The following is a description of a gene set: Human Gene Set: FAN_OVARY_CL15_SMALL_ANTRAL_FOLLICLE_GRANULOSA_CELL studied in species Homo sapiens The GC of small antral follicles (1-2_mm diameter) clustered pronouncedly in cluster (CL15) showing WT1high/EGR4high/VCANlow/FSTlow expression (Fig. 4b), suggesting that at that stage mural and cumulus GC still have a common progenitor (pGC) signature. from publication Fan X, Bialecka M, Moustakas I, Lam E, Torrens-Juaneda V, Borggreven NV, Trouw L, Louwe LA, Pilgram GSK, Mei H, van der Westerlaken L, Chuva de Sousa Lopes SM (PMID 31320652), and this is the list of marker genes: STMN1, RPL17, PHF6, ANKRD10, MT-CO1, PPP1R13L, NXF1, ACSL3, ARF5, SMARCA1, SOX4, DNAJB6, DYNLL1, PMAIP1, METAP2, GADD45B, TCEA3, VPS29, TOR1AIP2, ARPC5L, MIF, SMNDC1, ELOB, HIKESHI, SKIL, ACTB (actin beta), NR5A2, MTCH1, DCTN6, EGR3, NDUFA4, TCP1, CFAP20, NOP58, AMHR2, SERTAD3, ZBTB10, MAPRE1, SNRPF, MT-CO2, PABPN1, LSR, MFAP2, HNRNPA1, JPT1, H4C3, MOAP1, LMBR1L, BCL2L12, GHITM, ISYNA1 (inositol-3-phosphate synthase 1), ZFAND6, THAP9-AS1, ANXA6, TMEM41B, GMNN, ACADM, FUBP1, NDUFB6, BZW1, AKIRIN2, LUC7L3, TCEAL2, AKIRIN1, MGST3, LY6E, RASL11B, CYRIB, BUD31, HOPX, SQLE, RBM39, DUOX1, CHRM3, SNRPG, ATP1B1, UBE2D3, CDK6, FNDC3B, CAMTA1, EIF4G2, TIMM17A, ARPC5, CTNNAL1, ZNF711, KRT18, STK17B, MYL12B, CPSF6, PSMA3, CDH3, HIF1A, HSP90AB1, STIP1, SNRPE (small nuclear ribonucleoprotein polypeptide E), SINHCAF, NME2, RANBP1, MT-ND3, DYNLT1, SAT2, HSD17B1, PFN1, FBXO32, IFT25, USP9X, U2SURP, SARNP, BAMBI, KDM5A, DSP-AS1, STRAP, MAGED2, CHSY1, RABGGTB (Rab geranylgeranyltransferase subunit beta), MYO10, SNRPN, MTRF1L, GNAI3, FRMD4B, HIGD1A, YTHDC1, RAB2A, PPP2CA, SRPX, ARIH1, PNRC2, CD164, EGR4, SRI, ARL4D, METTL21A, RALB, RBM7, EFNB2, MAFF (MAF bZIP transcription factor F), CKS2, ATP5PF, IFI27L1, NCKAP5L, HNRNPH1, EXT1, ATP5MG, HMGCR, TMEM97, APOA1, INHBB, CHIC2, TAX1BP1, KIF1B, RBBP7, TJP1, PDZRN3, SUMO1, KPNA3, PSPC1, PPP1R14A, SOWAHC, YWHAB (NCBI Gene Id 7529), ATP1A1, MARCKSL1, ZNG1B, ZNF326, UQCRH, IFNGR2, CCNL1, DPM1, OSGIN2, G3BP2, PRDX2, IST1, SLC16A1, RAD23B, ODR4, TPRKB (TP53RK binding protein), PRKAR2B (protein kinase cAMP-dependent type II regulatory subunit beta), ME2, THUMPD3-AS1, MARK3, HSPE1, WASF3, CSPP1, MAP3K13, DNAJA4, PFDN4, SLC25A5, ACTG1, RUNX1, SRSF10, POR, SF3B6, TEAD1, BEX1, OSER1 (oxidative stress responsive serine rich 1), PTGER2, DIPK2A, AHSA1, WT1, SNRPB, RBM8A, NECTIN2, MARCHF7, CDKN2AIP, ARHGAP18, SKP1, FOSL2, PDRG1, TSC22D2, PAIP1 (poly(A) binding protein interacting protein 1), PPP1R15A, SLC39A8, HNRNPM, DSP, LSM5, PPA1, RBP1, MED13L, DNAJB1, B3GNT2, EEF1B2, MSH6, CCND2, HNRNPK, HSBP1, CKB, COX7B, RCN2, UBC, ARF4, MARCHF5, TMEM14A, CBX3, PLIN3, ARPC2, ZFAND2A, INHA, ATG101, AK6, CLK1, ACSL4, NBEAL1, AJUBA, TMEM126A, MPC2, PSMD14, LUC7L, USP16, RNMT, AFF4, HOMER1, HSP90B1, RPRD1A, ZC3HAV1, YAF2, TIMM23, COMT, BCAR3, NICOL1, MGARP, LAPTM4B, RPL27A, GPR89B, LRRC8C, DDX52, ZNF593, TMEM60, GRIK1, GNAI1, ARL6IP1, P3H2, DNAJA1, NET1, ZFAND5, MT-ND4L, PRDX3, HSP90AA1, IFRD1 (interferon related developmental regulator 1), PPP1R12B, KHDC4, SMS, TRMT112, NR4A1, PHEX (phosphate regulating endopeptidase X-linked), MCL1, TMEM41A, ST3GAL4, EMX2, MTMR14, ATG3, ID3, BCAT1, SPINT2, AKAP9, TRA2A, BANF1, SLC25A3, RCHY1, CCT5, ERG28, RAB5IF, MARCHF6, ATP5F1B, EWSR1, THBS1, ZNF428, TFG, ATP5IF1, TWSG1, MRPL47, HERC2, MAP4K4, CTSV, HK1, UBE2N, RPL37A, PUM1, ADNP, CSRP2, TUFT1, GADD45A, ACP1, HSPA1B, TXNL1, ARID4A, TNPO3, CENATAC, CCT2, SEM1, EBPL, PLA2G12A, CCDC34, RBM22, SNAPC1, ZNF275, ERH, ADIPOR2, HSPH1, ARL5B, PNN, MICOS10, SLCO3A1, SCYL2, RPS25, SCD, UQCC2, GOLPH3, LGR4, HSPA1A, TBC1D23, NACA2, DCUN1D5, CCT6A, SLC12A2, TPR, WSB1, NUFIP2, MYLIP, ING3, AZIN1, CALM2, SUB1, MT-CO3, POMP, KPNA2, CITED2, RANGAP1, UBE2C, EIF5, PTOV1, TARS1, FSCN1, TPI1, SARAF, ENC1, HSPA14, DDX5, DMAC1, FUBP3, SERPINH1, PRPF38B, MEST, RNF19A, HNRNPA1L2 (NCBI Gene Id 653821), PIP5K1A (phosphatidylinositol-4-phosphate 5-kinase type 1 alpha), HSPD1, UBE2A, ETNK1, NME4, TUBB2A, YWHAE, BUD23, RYBP, PPP4C, PGM2, PPP1R15B (NCBI Gene Id 84919), PCBP1, ATP5MC2, KRT8, IRS1, LAPTM4A, HMGB3, CACYBP, PSMD12 (NCBI Gene Id 5718), CTNND1, MTMR2, PPM1B, MACROH2A2, MYL12A, FGD4, CKAP2, UBALD1, IDI1, SCG5, ZNF814, MIDEAS, MYL6, SNHG15, PTS, DNPH1, MIR202HG, WIPF3 (NCBI Gene Id 648464), SEH1L, PRR14, FKBP3, GATA6, GATA4, LRAT, S100A10, PPM1D, EIF1AD, TSPAN7 (NCBI Gene Id 7102), FDFT1, SRSF2, GATM, WASF1, H2AX, GNL1, GRB14, PRPF40A, G0S2, SERTAD1, RBBP6, SRSF9, HES1, MIDN, UBE2D1, ATF7IP2, TXNDC17 (thioredoxin domain containing 17), SEC14L1, FDXR, G6PD, CNN3 (NCBI Gene Id 1266), ACIN1, WEE1, CCN2, AMH, RHOB, SEC61G, UBXN8, ACSM3, KLF10, HUWE1, DNAJB11, PLAAT3 (NCBI Gene Id 11145), MED6, HAPSTR1, NDUFB9, HSPA4, LCMT1, YWHAH, U2AF1, VDAC2, ANKH, YAP1, RPL39, AMOTL2, PHLDA1, SMARCD3, PAFAH1B3, TXNDC12, MRPL18, WAC, TRA2B, ETF1, RRN3, RIMKLB, MAGED1, LATS2, CHTOP, KLHDC8B, DEDD2, FXR1, CHORDC1, LEPROTL1, EZR, ATP5F1C, SLU7, TBCA, LSM7 (LSM7 homolog, U6 small nuclear RNA and mRNA degradation associated), LIPH, IP6K2, GJA1, TAB2, MAOA, ING1, NDUFS5, PCBP2, HSPA6, IGF2BP2, SNRPA1, IVNS1ABP, AFG2B, COX7C (NCBI Gene Id 1350), DAAM1, PLAT, DYNLT2B, PRMT1, MLF2, RBMS1, SLC25A33 (NCBI Gene Id 84275), PTRHD1, MAGOH, TMSB10, GPAT3, ZCCHC10, TXNRD1, IER2, RPAIN, TOP1, NDFIP1, RIN2, REV3L, ITGAV, DUSP14, PDLIM5, TNNI3, CHL1, CMTM8, REEP6, CD83, LPL, C6orf62, EZH2, COPS5, BEX3, C1orf52, HNRNPA2B1, NDUFA7, MIR22HG, FAM210A, ZC3H15, RAB5A, FILIP1L, SRSF3, MOSPD1, EPDR1, CCT4, YME1L1, ASXL1, OLA1, EML5, NRIP1, ATF3, CRNDE, NDUFA1, BAG3, DSEL, PRDM1, ARID4B, TMEM176B, GSTA1, HSPA8, SRP9, SERPINE2, TAF1D, PTTG1, FHOD3, CYCS, ITFG1, TMEM106C, ID4, H2AZ1, NFE2L2, TPM3, CTNNB1, RSRC2 (arginine and serine rich coiled-coil 2), MATCAP2, SYNE2, TXN2, CFI, KLF6 (NCBI Gene Id 8025), HNRNPC (heterogeneous nuclear ribonucleoprotein C), RPS26, TOB1, PSMB7, CLIC1, TPD52, YBX3, SDE2, SFPQ, KTN1, GADD45G, RIOK3, VAPA (VAMP associated protein A), CDH2, CSRNP1, RHEB, EIF4A1, IQCG, CCDC47, PPHLN1, UQCRHL, PTP4A1 (NCBI Gene Id 7803, protein tyrosine phosphatase 4A1), HNRNPDL, DNAJB4, HDAC2, PHPT1, USP48, HMGCS1, CD55, MYO1B, BEX5, RBM25, PGM1, F3, CD47, MRPS18C, USPL1, SGK1, NAV2, PSMA4, TCEAL9, NDUFS4, ACTR3, MBIP, PRAME, CD59, ATP5MJ, UBL5, CCN1, DBI, JMJD6, HEY2, ITGA6